The following is a description of a gene set: studied in species Homo sapiens Genes down-regulated in multipotent progenitors versus CD4 T cells. Human Gene Set: GSE37301_MULTIPOTENT_PROGENITOR_VS_CD4_TCELL_DN from publication Ramirez K, Chandler KJ, Spaulding C, Zandi S, Sigvardsson M, Graves BJ, Kee BL (PMID 22608498) Expression profiling of Rag2-deficient Ets1++ and Rag2-deficient Ets1-- mature NK cells and WT bone marrow progenitors, WT T cells, and WT Pro B cells, and this is the list of marker genes: SH3BP5, HERC1, ATP5F1C, FBXO21, IPP, AMOTL2 (angiomotin like 2), FAH, COX7A2, CPEB2, TIMP2, WDR13, IGF1, NEDD1, ANKRD13C, TIMM8A, PRUNE1, TMEM150A, C1orf43, COX6C, RNF34, HK1, NRBP1, DPP8, MTSS2, JCHAIN, ATXN10, ZNF276, C6orf89, HSD3B7, PRDX5, CDH2, TIMM17B, GMNN, ADK, EVI5, CDC7, CA8, PMP22, CFHR2 (NCBI Gene Id 82725), ADH1C, MBL2, TSPAN12, TRAPPC3, TSFM, RGS5, MCM7, ZBTB22 (NCBI Gene Id 9278), BGN, CCNI, LPL, GCAT, ATOX1, KDELR2, ZDHHC6, ITGB1, WDR20, RBM4B, RBP1, BCL2L2, MRPL23, GOT1, NDUFC1, RBBP7, CS, FAM107B, STK38, ACP2, CYP3A7, RNF13, PRKACA, MRPL34, IL11RA, MAP4K2, CARD19, UGT2B10, SLC50A1, BSCL2, FBXO45, CTSF, ATP2C1, F8, KIF1C, PRKD3, RTF2, MTFR1L, VCL, IMPA1, NDRG3, RXRA, PTPRB, ATRAID, SIGMAR1, TNRC6A, MDH2, OGFOD2, FAM162A, FTL, PPP1R21, DAZAP2, AADAC, GJB1, UBE2H, LPP-AS2, PPIA (NCBI Gene Id 5478), HPD, UGP2, ATP6V1E1, RNF6, FKBP3, CENPB, STXBP2, NIT1, DEF8, SCG2, C6orf136, RNF141, RPA1, NR3C1 (nuclear receptor subfamily 3 group C member 1), ITGB3, WBP1, UNC45A, SLC7A3, NXF1, PAFAH2, TTR, VPS35, APOC2, C5, SYT1, KLC4, DDC, SEPTIN9, TNK2, REV3L, TSSC4, HTATIP2, CNOT1, XPC, MRPL35, KLHL9, SFXN2, HP1BP3, PEX11B, NTHL1, NAA35, ANKRD46, CES1, ARHGAP35, MTPN, FGGY, IFT27, RPS25, ATRX, SLC29A1, ABCC2, ATP5IF1, FBXO8, RMND1, AGT, RPL10, NDUFB11, FMO1, NDUFA13, SMIM20, MLX, VPS28, IP6K1, TIMM13, HOXA10, TMCO1, ZNF32, EBP, UBC, CRIPT, SH3BGRL2, MFGE8, TMX2, NIT2, IGFALS, ATXN2, PDLIM1, B3GAT3, MED24, RNF138, CRCP, GTF2A1, CKS2, RBBP9, GRPEL1, BNIP3L, MRPS31, PGAM1, RETREG2, DCTPP1, SMARCE1, HAGH, LGALSL, DSP, NCOA4, MARCKS